Given this list of marker genes ZWINT, KNL1, PIWIL2, DMRT1, WEE2, PSMA8, here is a description of the gene set: Human Gene Set: GOBP_REGULATION_OF_MEIOSIS_I species: Homo sapiens Any process that modulates the rate, frequency, or extent of meiosis I, a cell cycle process comprising the steps by which a cell progresses through the first phase of meiosis, in which cells divide and homologous chromosomes are paired and segregated from each other, producing two daughter cells.